The following is a description of a gene set: Productive rearrangement of the immunoglobulin heavy chain locus triggers a major developmental checkpoint that promotes limited clonal expansion of pre-B cells, culminating in cell cycle arrest and rearrangement of the kappa (κ) or lambda (λ) light-chain loci. B lineage cells lacking the related transcription factors IRF-4 and IRF-8 undergo a developmental arrest at the cycling pre-B cell stage and are blocked for light-chain recombination. Using Irf-4,8-/- pre-B cells we demonstrate that two pathways converge to synergistically drive light-chain rearrangement, a process that is not simply activated by cell cycle exit. One pathway is directly dependent on IRF-4, whose expression is elevated by pre-BCR signaling. IRF-4 targets the κ 3′ and λ enhancers to increase locus accessibility and positions a kappa allele away from pericentromeric heterochromatin. The other pathway is triggered by attenuation of IL-7 signaling and results in activation of the κ intronic enhancer via binding of the transcription factor, E2A. Intriguingly, IRF-4 regulates the expression of CXCR4 and promotes the migration of pre-B cells in response to the chemokine CXCL12. We propose that IRF-4 coordinates the two pathways regulating light-chain recombination by positioning pre-B cells away from IL-7 expressing stromal cells. We used microarrys to identify the changes in gene expression under different levels of the cytokine IL-7 and after rescue of genetic defect. Genes up-regulated in IRF4 and IRF8 null pre-B cells treated with 0.25 ng/ml IL7 versus the cells treated with 5 ng/ml IL7 and transduced with IRF4. from publication Johnson K, Hashimshony T, Sawai CM, Pongubala JM, Skok JA, Aifantis I, Singh H (PMID 18280186) studied in species Homo sapiens Human Gene Set: GSE10273_LOW_IL7_VS_HIGH_IL7_AND_IRF4_IN_IRF4_8_NULL_PRE_BCELL_UP, and this is the list of marker genes: WDR48, F2, RBBP8, CYB561A3, B3GNT5, CNIH2, SMARCC1, BST1 (NCBI Gene Id 683), GALK1, TAF6L, AARSD1, OPRM1, CDCA7L, RHBG, DDIAS, CKS2, ASAH2, GUSB, CASR, SIGLEC10, CKAP4, TMEM106C, SLFN12, SYT4, CASK, HYOU1, SNHG32, RCC2, KDM2B, AUNIP, SMARCA4, ADGRL2, SNRPD1, TEDC1, CXXC5, DHRS3, SUV39H1, ERCC6L, CHAF1B, LMNB2 (NCBI Gene Id 84823), ARHGAP21 (NCBI Gene Id 57584), KIFC1, ATAD3A, OAF, CTC1, ADAM9, ENDOU, NECTIN4, ADA, CTTNBP2NL, SHH, MTM1, ZBED5, MAGEA11, TYRP1, MAPK6, SSRP1, KRTAP2-4, WHRN, PPM1G, WDFY4, CASQ1, SNN, CIT, ABI2, SCNN1A, NLN (neurolysin), DNAL1, HDGF, PTCD3, SHMT1, RFC4, CDKN1A, AGPAT1, FIRRM, SELENOT, IL17RE, CD180, SLC25A1, TEX47, MRPL55, HAND2, PHKA1 (phosphorylase kinase regulatory subunit alpha 1), PLK2, JADE3, TMTC1, PCK2, TIMM8A, ZFTA, RGN, C10orf90 (NCBI Gene Id 118611), PREP, GNL3, ASPM, POLE3, EPS8, RAD50, KHDRBS3, ZDHHC6, HOXC5, PRR15L, BRSK1, HOXD12, CTSE, TPRG1, SASH1, GAS2, CACYBP, LHFPL6, PPIH, BLZF1, ANLN, VMA21, CDCA5, WDR18, SPNS3, ERG, STMN1, DNASE2B, PRDX4, SDC4, LGR5, FAM110A, RBL1, GALNT14, PRELID3A, GIPR, BEST2, ZNF503, RANBP1, ZNF22, GLYAT, SPATA7, NASP, FCRLA, SUZ12, FAM98B, POU2AF1, SDC3, APOOL, NDC80, STAC2, CCDC86, CCDC159, EIF2A, CDK4, PMF1, MFSD12, GMPR, SOX12, RNF157, CACNA2D1, RNMT, CNN1, MYLK, LGI1, SDR42E1, FNDC8, TACC3, SLC29A1, CENPP, ENPP6, GGA2, IL1RN, PAFAH1B3, SUMO3, HMGB2, IPO5, PLAC8, EPRS1, PRKCD, LYL1, LRRC40, SKA3, SPI1, SPIB, HK2, CHSY1, EYA1, BAG2, SMTN, OLA1, SEC14L5, CHEK1, TMEM69, LRRC49, TCF4, IFNLR1, ARHGAP28, EME1, SLBP, KIF22, ATG4C, OR51B2, CASS4, FNDC5, MUTYH, DBF4, PSMD1, CPSF2